Given this list of marker genes ARL11, BAG3, RHOBTB2, MON1A, RASGRF2, KANK3, ZBTB48, CFL2, GTF2IRD2, CCDC115 (coiled-coil domain containing 115), LDHB, UCK1, PHETA2, PLK3, ASB1, LPAR2, EPHB2, CLK2, COA4, PLA2G2E, YPEL2, RABGGTB, TENT4B, HOXA1, OSGIN1, MFAP3, XPC, CASP9, NPTN, SAC3D1, EFNB1, SNAPC3, BBS10, TRUB2, MLYCD, BRF1, GOLPH3L, NLRP10, AGPAT2, FGF11, NLRX1, CCDC61, RNF169, KDM2A, CLIP2, TTBK2, B4GALT6, RUSC1, AACS (acetoacetyl-CoA synthetase), CBL, THUMPD2, B3GNT8, LSM14B, AGFG2, ASXL2, LATS2, FOXO3, EIF4A2, PAIP1, ZFAND2A, FLCN, PPIL4, GALE, CCL25, ARL4C, SMURF2, ARRDC2, SAMD10, ARHGEF10L, KAT6B, CCDC126, CELSR3, SLC5A6 (NCBI Gene Id 8884), FOS, RIPOR1, FAM78A, MIB2, SH3YL1, PWWP2B, BBS1, EEF1A2, NMNAT1, HYI, HDAC7, LYL1 (NCBI Gene Id 4066), MED17, DUS3L, TTC33, NT5DC3 (5'-nucleotidase domain containing 3), SLF2, ZNF394, DGKI, ABHD8, RPL30, PDE4DIP, XPR1, NHLRC3, MSL1, C16orf54, MRPL49, PPP1R12C, KCTD7, PLEKHA1, DNAJC5, PRRC1, EIF1B, MCRIP2, ARHGAP33, CAMSAP2, CIB3, ANGPT2, MGMT, GTPBP3, RHOV (NCBI Gene Id 171177), MFF, CEP97, METTL13, UBE2O, CACNB1, UQCC3, NAALADL1, PCGF1 (polycomb group ring finger 1), INO80B, ZSCAN2, BLOC1S3 (NCBI Gene Id 388552), SLC25A42, ERCC5, CCDC127, CNR2, HMGCS1, RPRD1A, ID1, MAFB, RAB31, FBXW2, CDIPT (CDP-diacylglycerol--inositol 3-phosphatidyltransferase), NR2F6, THNSL1, PATZ1, PLA2G5, IFFO1, VAMP2, FAHD1 (fumarylacetoacetate hydrolase domain containing 1), THAP11, TBC1D2, ARID3B, TSEN2, MIB1, TRIM65, C7orf25, EPM2AIP1 (EPM2A interacting protein 1), TRIM68, VAMP1, FBXO10, PSMA8, GTSF1, here is a description of the gene set: from publication Hoffmann R, Lottaz C, Kühne T, Rolink A, Melchers F (PMID 17890238) Genes down-regulated during B lymphocyte differentiation: pre-B I versus large pre-B II. Cells from four develppmental stages were purified by FACS from human bone marrow samples species: Homo sapiens Human Gene Set: GSE4590_PRE_BCELL_VS_LARGE_PRE_BCELL_DN